The following is a description of a gene set: Mouse Gene Set: GOBP_NEUROPEPTIDE_SIGNALING_PATHWAY species: Mus musculus A G protein-coupled receptor signaling pathway initiated by a neuropeptide binding to its receptor on the surface of a target cell, and ending with the regulation of a downstream cellular process., and this is the list of marker genes: Nps, Rxfp4, Nmur1, Npy4r, Tenm1, Npsr1, Gpr37, Mchr1, Ecel1, Sstr4, Mrgpra4, Oprm1, Cckbr, Npy, Gpr171, Hcrtr2, Qrfpr, Penk, Cartpt, Pyy, Npy6r, Pth2, Prlhr, Adcyap1, Pmch, Grp (NCBI Gene Id 225642), Pomc, Tyro3, Nmbr, Cmklr2, Cort (cortistatin), Ecrg4, Nts, Ntsr1, Sstr5, Ppy, Grpr, Nmur2, Gpr143, Oprd1, Sort1, Pnoc, Gpr149, Agrp, Oprk1, Prokr1, Ltb4r1, Npy2r, Gpr84, Gpr83, Ptgdr2, Sstr1, Gipr, Glrb (glycine receptor, beta subunit), Rxfp3, Pdyn, Oprl1, Kiss1r, Uts2r, Npff, Gal, Gpr139, Crhr1, Npvf, Calca, Ntsr2, Nmu, Npbwr1, Glra1, Galr1, Galr3, Ltb4r2, Pcsk1n, Mrgpra1, Qrfp, Ucn, Sorl1, Crcp, Prokr2, Cysltr1, Cysltr2, Hcrt, Glp1r, Nppb, Nppa, Hcrtr1, Prok2, Nms, Npffr2, Sstr2, Tac2, Npy1r, Sstr3, Npy5r, Galr2, Scg5, Rapgef2, Nmb, Gpr165 (NCBI Gene Id 76206), Npb, Ucn3, Galp, Glra2, Mc2r, Tac1, Rela